The following is a description of a gene set: Reactome Pathway: Toll Like Receptor 9 (TLR9) Cascade part of: Toll-like Receptor Cascades CpG DNA is an unusual Pathogen-Associated Molecular Pattern (PAMP). Cytosine methylation exists in mammalian but not bacterial cells, and most (but not all) CpG in the mammalian genome is methylated. Therefore, unmethylated CpG DNA may signal the presence of microbial infection. Evidence of CpG recognition by TLR9 was demonstrated both in human and mouse, and this type of signaling requires its internalization into late endosomal/lysosomal compartments. TLR9 has been reported to be able to discern different types of CpG motifs, and therefore that it presumably recognizes CpG DNA directly. It appears that over evolutionary periods, TLR9 molecules expressed by different species have diverged. This has led to differences in the precise sequence motif (CpG dinucleotide plus flanking regions) that optimally stimulate the innate immune system of different animals. species: Homo sapiens, and this is the list of marker genes: MAP2K3, NKIRAS2, RPS6KA1, CREB1, RPS27A, CHUK, PPP2R1B, TAB3, SLC15A4, LRRC14, MAP2K4, IKBIP, MAPK3, MAP3K1, NFKBIB, NFKB2, NFKBIA, UBB, MAPK11, FBXW11, NLRC5, MEF2A, NOD2, MAPKAPK2, MYD88, CUL1, TLR7, IRAK1, RIPK2, NLRX1, MAPK8, MAPK9, SAA1, MAP2K6, ATF2, S100A12, IRAK2 (NCBI Gene Id 3656), MAP2K7, PELI1, TASL, TLR9, NOD1 (NCBI Gene Id 10392), ELK1, UBE2N, AGER, PELI3, TIFA, IRF7, MAPK1, UBA52, EEA1, PPP2R5D (NCBI Gene Id 5528), JUN, MAPK10, NFKB1, MEF2C, IRAK4, PIK3R4, PPP2CB, DUSP6, IKBKG, NKIRAS1, TP53, BTRC (beta-transducin repeat containing E3 ubiquitin protein ligase), USP14, TLR4, MAPK7, N, PPP2CA, TNIP2, TAB2, SKP1, RPS6KA5, IKBKB, DUSP3, APP, MAPK14, TRAF6, PIK3C3, MAP2K1, HMGB1, RPS6KA2, ATF1, ALPK1, UBC, TICAM2, USP18, MAP3K7, DUSP4, MAP3K8, TAB1, VRK3, PELI2, DUSP7, RBSN, PPP2R1A, ECSIT, MAPKAPK3, CD14 (NCBI Gene Id 929), FOS, LY96, UBE2V1, TRAF2, S100B, CASP8, RELA, N4BP1, IRF5 (NCBI Gene Id 84729), RPS6KA3, TICAM1